The following is a description of a gene set: Mouse Gene Set: GOBP_REGULATION_OF_HIPPOCAMPAL_NEURON_APOPTOTIC_PROCESS Any process that modulates the occurrence or rate of cell death by apoptotic process in hippocampal neurons. species: Mus musculus, and this is the list of marker genes: Draxin, Stambp, Cx3cl1, Trem2, Lcn2, Cx3cr1